Given this list of marker genes Slc27a1, Cyp1b1, Irf1, Epha2, Mir143, Gria1, Grb14 (growth factor receptor bound protein 14), Ret, Obp2a, Jak1, Pip4k2a, Gper1, Dennd4c, Fam114a1, Rangap1, Slc39a14, Ctnnb1, Stat3, Pdgfrb, Tyk2, Ghsr, Irs4, Blvrb, Met, Stxbp4, Epha7, Rap1gds1, Bglap2, Ghr, Adipoq, Prkcz, Tbc1d4, Rab31, Slc2a4, Rela, Myo1c, Jak2, Eprs1, Glp2r (glucagon-like peptide 2 receptor), Pklr, Rock2, Slc26a6, Gdf15, Prkd1, Sos2, Il18, Cyp11a1, Eif4ebp2, Cyp11b1, Dnai1, C2cd5, Vamp2, Uchl3, Scnn1b, Got1, Grb7, Lpl, Kat2b, Tnf, Wnt1, Bglap3, Myo5a, Gsk3b, Cyp11b2, Igf1, Pdpk1, Sgcb, Nono, Prkcd (NCBI Gene Id 52581), Gjb2, Ntrk2, Gkap1, Pten, Csrp3, Erbb2, Tsc2, Ncoa1, Gcg, Crhr1, Adipor1, Syap1, Ptpra, Mgarp, Raf1, Tek, Ddr2, Gpld1, Rps6kb2, Uso1, Ednra, Mtor, Csf1r, Ggcx, Mup1, Gck (NCBI Gene Id 14624), Lonp1, Appl2, Ntrk1, Igf1r, Prkci, Ide, Epha10, Srsf3, Erfe, Ephb2, Nr3c2, Insig2, Ceacam2, Ncl, Eif4ebp1, Fer, Inhbb, Ntrk3, Rac1, Capn10, Usf1, Hmgcs2, Map2k1, Hdac9, Pak1, Ankrd26, Irs2, Zfp106, Prkar1a, Flt4, Agtr1b, Pik3ca, Ins1, Igf2, Agtrap, Stat5b, Ptk2, Stat5a, Sorl1, Pdk4, Ctsd, Rps6kb1, Adrm1, Pik3r2, Nkx6-1, Nucks1, Edn1 (endothelin 1), Epha1, Pid1, Ywhag (tyrosine 3-monooxygenase/tryptophan 5-monooxygenase activation protein, gamma polypeptide), Pik3r1, Scnn1g, Apc, Ptpn1, Lpin1, Tgfb1, Umodl1, Fgfr1, Egfr, Mfn2, Pxn, Plcb1, Ucp2, Max, Hsf1, Cfl1, Grb2, Ass1, Cps1, Foxo4, Pou4f2, Insig1, Sesn3, Rab10, Zfp592, Rarres2, Rock1, Actn2, Fos, Irs1, Akt2, Fgfr3, Ptprv, Ptpre, Pik3r3, Prkaca, Gpt, Ceacam1, Sirt6, Erbb4, Sos1, Adcy8, Pcsk9, Ace, Shc1, Prkca, Epha8, Echdc3, Enpp1, H2az1, Zdhhc7, Gstp1, Tyro3, Bglap, Socs1, Alk, Gnas, Ndel1, Brip1, Mst1r, Wdtc1, Ltk, Fgfr4, Cdk2, Ptpn2, Axl, Inppl1, Parp1, Inpp5k, Cyfip1, Ptpn11, Srebf1, Ghrhr (NCBI Gene Id 14602), Mapk3, Ccl2, Mtcl2, Fbxw8, Glp1r, Serpina12, Smarcc1, Itgb3, Scnn1a, Mup2, Akt1, Ddr1, Leprotl1, Rhoq, Musk, Mas1, C1qtnf9, Lpin3, Epha3, Mir494, Flt1, Prkdc, Mdm2, Zbtb7b, Camk2a, Ros1, Cpeb2, Stat6, Ahsg, Il1b, Csk, Gsk3a, Ins2, Mup3, Opa1, Nr1h4, Nr4a1, Crhr2, Pdgfra, Phip, Slc30a10, Snx5, Hras, Gclc, Pck1, Rb1, Map1b, Ephb3, Jak3, Nr4a2, Hmga1, Ahcyl1, Ptprf, Pip4k2b, Fut7, Sirt1, Pde3b, Pdk2, Foxo1, Shoc2, Akt3, Hnrnpk, Socs3, Trib3, Crhbp, Tshr, Gnai2, Kdm6a, Kank1, Cul3, Ppp3ca, Ephb1, Rab13, Lpin2, Bcar1, Prkcb, Sgk1, Tns2, Nck1, Akr1c18, Agtr2, Epha4, Ncoa5, Mup5, Mapk1, Trarg1, Epha5, Irs3, A1bg, Kit, Cul7, Sco1, Socs2 (NCBI Gene Id 216233), Gpam, Nfkb1, Col6a1, Fbp1, Ncoa2, Cpeb1, Vwa2, Lep, Epha6, Gpr21 (NCBI Gene Id 338346), Ephb4, Ccna2, Socs7, Foxc2, Star (NCBI Gene Id 52131), Pip4k2c, Pparg, Leprot, Mup11, Insrr, Slc27a4, Crk, Sorbs1, Fgfr2, Pkm, Bcar3 (breast cancer anti-estrogen resistance 3), Gpr173 (G-protein coupled receptor 173), Ror2, Reg1, Nr4a3 (NCBI Gene Id 18124), Lhcgr, Osbpl8, Marcks, Pax6, Car2, Cav2, Trim72, Anxa5, Otop1, Blvra, Slc2a8, Atp2b1, Sik2, Kbtbd2, Gcgr, Ptprj, Insr, Map3k7, Src, Inhba, Sp1, Ang2, Ogt, Appl1, Gh (growth hormone), Rab8a, Mstn, Cav1, Xbp1, Esrra (NCBI Gene Id 269047), Mapkap1, Tie1, Mup4, Nucb2, Rbm4, Gnrhr (NCBI Gene Id 14715), Eef2k, Slc9a1, Ffar3, Flt3, Mertk, Grb10, C1qtnf12 (C1q and tumor necrosis factor related 12), Prkcq, Nfe2l2, Fbn1, Pck2, Prkaa1, Zfp36l1, Grk2, Agt, Sh2b2, Igfbp1 (insulin-like growth factor binding protein 1), Rbx1, Mzb1, Slc25a33, Adcy6, Kdr, Mbd5, Agtr1a, here is a description of the gene set: Any process that results in a change in state or activity of a cell (in terms of movement, secretion, enzyme production, gene expression, etc.) as a result of a peptide hormone stimulus. A peptide hormone is any of a class of peptides that are secreted into the blood stream and have endocrine functions in living animals. Mouse Gene Set: GOBP_CELLULAR_RESPONSE_TO_PEPTIDE_HORMONE_STIMULUS studied in species Mus musculus